Given this list of marker genes LRRC15, GRHL1, DSPP, PRRC1, EREG, ATP13A4, RORA, LRP2, TPM2, CHCHD7, MAP2K5, ZNF354A, RALGPS2, SPMIP5, LRP1, ABLIM2, FBXW7, DNMT3B, NKX2-1, H3-3B, HMGN2, MAML3, FGF10, NRL, EIF4E, HTR3B, PCDH9, RNF111, MYO18A, UBQLN1, PRR34, SHOX2, HOXB6, SORBS2, ATP11C (NCBI Gene Id 57206), ZNF423, WDR33, NEUROG1, MAB21L2, MINK1, ACP6, INPPL1, LMO4, HDAC9, FGF3, TCL1A, GAD1, CNNM2, APCDD1L, COL12A1, MEIS2, TMEM126B, RGS12, SLC16A6, TET1, PAX2, SULF1 (NCBI Gene Id 23213), C7orf33, RWDD2A, WNT8B, KLF12 (KLF transcription factor 12), ALX1, SMAD6, SOHLH2, GNG8, TBXAS1, NAP1L5, MSI2, HOXA3, NRXN1, PRKAB1, STAT3, SYNRG, ALKBH5, KCTD15, C1orf122, WIPI1, PLPP3, DOCK4, SRSF7, RNF39, FLT1, CHRNA10, DNAJB4, FOXP2, CEP120 (centrosomal protein 120), LINC00303, USP40, MBNL2, ESRRG, GABARAPL2, ECHDC2, ZNF277, CER1, TAB2, ADGRL2, CBLN4, OTP, WNT10A, FGF7, JDP2, PLAG1, TBR1, LINS1, LNPEP, SKAP1, KLF6, SLC6A15, TCF12, TMEM182, HOXC6, GPRC5D, HSPB3, BBOX1, ANK3, GJA1, TRIM24, VGLL1, HPSE2 (NCBI Gene Id 7354), POMC, SLC25A25, CEP41, HS3ST2, IMPDH2, TMEM178A, HHIP, NHLH2, KCNH5, ZDHHC21, CTSK, RCC2, OPN1LW, PCNT, ASB7 (ankyrin repeat and SOCS box containing 7), DAB1, MOSMO, DNAJC5B, INA, ARHGEF10L, ROBO3, CNTN4 (NCBI Gene Id 53943), SPINK6, NEO1, KCNJ3, LTBP1, NOTCH1, CXCL14, LRP1B, KCTD12, BAIAP2L2, MUC15, TAFA1, ATOH1, YRDC, AQP3, SEZ6, FLNA, FBXW11 (NCBI Gene Id 23291), TRPM7, OTUD7B, NR4A3, RIOX2 (ribosomal oxygenase 2), FOXN3, TRPM1, UBXN10 (UBX domain protein 10), ARRDC3, GPR65, FGF19, NTRK2, DPF3, DLX1, TBX19, VIP, GNA13, PROK1, REEP4, EYA1 (EYA transcriptional coactivator and phosphatase 1), TBL1Y, ONECUT2, NECTIN3, DPH1, CFL2, LUC7L3, PDZRN4 (NCBI Gene Id 29951), PRMT5, LINC00311, ELAVL2, EN1, HOXC4, ANAPC15, CXXC4, S100G, SEZ6L, FLRT2, CDIN1, NSD1, LMO3, SEMA5B, GPC4, HSD17B2, EDEM1, HESX1, CRISP1, DMD, FAM53B, CACNA1C, ATF7, PAX3, SLC6A5, TFAP2D, CITED2, POU2F1, KRT222, DCX, ENSG00000291228, UBE2E2, RAB5B (RAB5B, member RAS oncogene family), HMGA2, DLX5, DLG3, UBR3, NELL2, CCDC149, ABHD17B, SYT9, VGLL4, RPL10, HOXD8, PDE7A, ROGDI, PTPN21, SIK3 (NCBI Gene Id 80236), TBL1X, EGLN1, SCML4, DNAJC22, PPM1E, TSPAN2, KLHL13, CA4, PITX2, PPFIBP1, PTPRC, WHRN, TENM3-AS1, MS4A1, HAS2, LINC02875, HOXC5, RNF11, SLC16A14, VLDLR, OSER1, PRRX1, CTLA4, GJD2, ANLN, EDA, SLC4A4, HTR2C, INHBA, KLHL1, AP1S2, PPP1R14C, PNOC, CYTH3, PHEX, here is a description of the gene set: studied in species Homo sapiens Human Gene Set: NKX25_02 Genes having at least one occurrence of the motif CWTAATTG in the regions spanning 4 kb centered on their transcription starting sites. This matches the NKX2-5 transcription factor binding site V$NKX25_02 (v7.4 TRANSFAC).